The following is a description of a gene set: Negative regulation of FGFR1 signaling species: Homo sapiens Human Gene Set: REACTOME_NEGATIVE_REGULATION_OF_FGFR1_SIGNALING, and this is the list of marker genes: RPS27A, FGF8, FGFR1, PTPN11, UBA52, FGF1, FGF4, CBL, FGF17, PPP2CA, FGF20, PPP2CB, SPRY2, FGF10, FGF22, UBC, MAPK3, FGF3, FRS2, UBB, MKNK1, PPP2R1A, FGF9, MAPK1, FGF23, KL (klotho), FGF6, FGF5, FGF2, GRB2, BRAF, SRC, ANOS1